Given this list of marker genes Eps15l1, Ston2, Synj1, Tbc1d5, Eps15, Ap2b1, Ap2m1, Cltc, Sgip1, Slc18a3, Btbd8, Clta, Ap2a1, Snap91, Cltb, Ap2s1, Ston1, Picalm, Dab2, Ap2a2, here is a description of the gene set: The coat found on coated pits and the coated vesicles derived from coated pits; comprises clathrin and the AP-2 adaptor complex. species: Mus musculus Mouse Gene Set: GOCC_CLATHRIN_COAT_OF_COATED_PIT